The following is a description of a gene set: Mouse Gene Set: GOBP_POSITIVE_REGULATION_OF_PROTEIN_KINASE_C_SIGNALING studied in species Mus musculus Any process that increases the frequency, rate, or extent of a series of reactions, mediated by the intracellular serine/threonine kinase protein kinase C, which occurs as a result of a single trigger reaction or compound., and this is the list of marker genes: Wnt11, Flt4, Vegfa, Cd40, Phlpp1, Adra1a, Wnt5a, Pla2g6